The following is a description of a gene set: Any protein maturation process achieved by the cleavage of a peptide bond or bonds within a protein. Protein maturation is the process leading to the attainment of the full functional capacity of a protein. studied in species Mus musculus Mouse Gene Set: GOBP_PROTEIN_PROCESSING, and this is the list of marker genes: Vsir, Tmem98, Gsn, F11, Klk1b16, Dhcr24, Ppp1r15a, Klk1b3, Tnp2, Myc, Sde2, Casp2, H13, Meltf, Timm17a, Aph1c, Ctla2a, Rps6ka2, Pgk1, Tll2, Oma1, Mme, Parl, Klk1b22, Pmpca, Cstl1, Klkb1, Mmp16, Anxa2, Atg4a, C2cd3, Fga, Adamts3, Klk1b27, Spcs2, Ace, Ero1b, Bag2, Capn2, Cpd, Tysnd1, Pik3c3, Plat, Hpn, Klk1b21, Il1r2, Pcsk9, Bace2, Pisd, Casp12 (caspase 12), Gas1, Myrfl, Tnp1, Ctsg, Ccbe1, Tmprss12, Tmprss4, Tll1, F3, Lgmn, Serpinf2, Spcs3, Snx12, Shh, C1rl, Asprv1, Atg4b, Anpep, Tmprss2, Fkrp, Ggt1, Cpa3, F9 (NCBI Gene Id 14071), Immp1l, Cpb2, Prkaca, Disp1, Serpine1, Phex, Ace2, Ctss, Ddi2, Zmpste24, Myh9, Atp6ap2, Hjv, Yipf5 (Yip1 domain family, member 5), Cpe, Chac1, Slc30a5, Pcsk6, Casp4, Klk1b4, Comp, Hsp90b1 (NCBI Gene Id 22027), Cpn1, Ctsz, Klk13, Tmprss9, Aph1b, Dhh, Psen1, Casp3, Sec11a, Cma1, C1ra, Srgn, Fam111a, Pitrm1 (NCBI Gene Id 69617), Cdh1 (NCBI Gene Id 12550), Prcp, Parp1, Pcsk4, Klk1b9, Astl, Gm15441, Vps35, Ldlrad3, Pthlh, Adam9, Sirt4, Actmap, Mafb, Mipep, S100a10, Inpp5b, Adam19 (NCBI Gene Id 11492), Scg5, Timm23, P4hb, Hp, Hgfac, Pmpcb, Ctsh, Corin, Ift88, Clec3b, Kel, Pcsk7, Pcsk1n, Hid1, Fuz, Klk1b26, Mmp14 (NCBI Gene Id 17387), Psen2, Cuzd1, Psenen, Adam17, Usp17le, Gli3, Cplane2, Mep1a, Adam10, Serpine2, Pidd1, Cpm, Fgb, Ins2, Mbtps1, Thbs1, Rnpep, Atg4c, Notch4, Src, Lrrk2, Fxn, C1rb, Ogt, Ctse, Enpep, H2bc1, Pcsk5, Ece2, Eno1b, Cln5, Glg1, Lonp2, Chst8, Ift172, Arxes1, Rhbdd1, Ptch1, Bmp1, Ihh, Cwh43, Atg4a-ps, Rfx4, Casp8, Nkd2, Casp6, Ece1, Aebp1, Klk1b8, Prss12, Prss37, Pcsk2, Prep, Eno1, Acp4, Ecel1, Cntn2, Pcsk1, Slc30a8, Atp23, Apoh, Ncstn, Sec11c, Fgg, Cpz, F12, P2rx7, Klk1b24, Klk1b1 (NCBI Gene Id 16623), Plau, Sppl3 (signal peptide peptidase 3), Nlrc4, Ctsl, Sprtn, Metap2, Spcs1, Naglu, Plg, Xpnpep3, Eef1ece2, Adamts2, Prkacb, Spg7, Cln3, Myrf, Mdm2, Klk1b5, Ift52, Ctnnd1, Aph1a, Ren1 (renin 1 structural), Afg3l2, Bace1, Afg3l1, Fmr1, Yme1l1 (NCBI Gene Id 27377), Mbl2, Mmel1, Stoml2, Rce1, Angptl8, Atg4d (autophagy related 4D, cysteine peptidase), Furin, Prss3b, Klk1, Klk1b11, Casp9, Arxes2, Rnf139, Dync2h1, Plgrkt, Spon1, Capn1, Immp2l, F7, Tmem208, Casp7, Casp1, Plaur